The following is a description of a gene set: Human Gene Set: HP_ABNORMAL_DENTAL_PULP_MORPHOLOGY Abnormal dental pulp morphology An abnormality of the dental pulp. studied in species Homo sapiens, and this is the list of marker genes: WRAP53, TERC, PEX6, DSPP, GREM2, IFT52, TINF2, BRF1, IRF6, USB1, DLX3, NOP10, MSX1, WNT10A, CPLX1, RTEL1, DKC1, TGFA, AXIN2 (axin 2), NF1, IFT43, EDA, NELFA, RAI1, ENAM, CHD3, TERT, IFT122, PARN, GALNT3, WNT10B, PEX1 (NCBI Gene Id 7788), NEK1, WDR19, FAM20A, PIGG, COL1A1, LETM1 (leucine zipper and EF-hand containing transmembrane protein 1), NPM1, COL5A1, EDARADD, CTC1, TP63, SUMO1, WDR35, NHP2, FGF3, DEAF1, PAX9, CTBP1, GJA1, SMOC2, NSD2, FGFR1, LAMB3, LRP6, COL5A2, IQSEC2, FLII, OCRL, TYMS (thymidylate synthetase)